The following is a description of a gene set: Persistent bleeding after trauma Human Gene Set: HP_PERSISTENT_BLEEDING_AFTER_TRAUMA studied in species Homo sapiens, and this is the list of marker genes: F9, FGA, FGB (NCBI Gene Id 2244), GATA1, F13B, VWF, DTNBP1, MCFD2 (NCBI Gene Id 90411), FGG, SERPINF2, SERPINE1 (NCBI Gene Id 5054), F5, F13A1, P2RY12, F8